Given this list of marker genes CALR, DDIT3, NFYB, HSP90B1, NFYC, NFYA, ATF6, XBP1, ATF4, HSPA5, here is a description of the gene set: Human Gene Set: REACTOME_ATF6_ATF6_ALPHA_ACTIVATES_CHAPERONE_GENES ATF6 (ATF6-alpha) activates chaperone genes studied in species Homo sapiens